The following is a description of a gene set: studied in species Homo sapiens Genes up-regulated in CD38+ CLL (chronic lymphocytic leukemia) cells. from publication Pepper C, Ward R, Lin TT, Brennan P, Starczynski J, Musson M, Rowntree C, Bentley P, Mills K, Pratt G, Fegan C (PMID 17287849) CD38 expression is an important prognostic marker in chronic lymphocytic leukemia (CLL) with high levels of CD38 associated with shorter overall survival. In this study, we used gene expression profiling and protein analysis of highly purified cell-sorted CD38(+) and CD38(-) chronic lymphocytic leukemia cells to elucidate a molecular basis for the association between CD38 expression and inferior clinical outcome. Paired CD38(+) and CD38(-) CLL cells derived from the same patient were shown to be monoclonal by V(H) gene sequencing but despite this, CD38(+) CLL cells possessed a distinct gene expression profile when compared with their CD38(-) sub-clones. Importantly, CD38(+) CLL cells relatively over expressed vascular endothelial growth factor (VEGF) and appeared to preferentially utilize an internal autocrine VEGF survival loop. Elevated VEGF expression was associated with increased expression of the anti-apoptotic protein Mcl-1. Inhibition of VEGF receptor signaling also resulted in a reduction in cell viability. In contrast, exogenous VEGF caused a significant increase in CD38(-) CLL cell viability and a marked induction of Mcl-1; both effects were less obvious in CD38(+) CLL cells. Taken together, our data provide a biological rationale for the poor prognosis of CD38(+) CLL and indicate that both VEGF and Mcl-1 may prove to be useful therapeutic targets. Human Gene Set: PEPPER_CHRONIC_LYMPHOCYTIC_LEUKEMIA_UP, and this is the list of marker genes: ATP10A, OR1E1, ADGRL1, CST3, HTR1B, RPE65, TYRP1, PTN, PGAP1, XYLB, LILRA1, VEGFA, DCAKD, IL1B, TLR3, PADI4, KIR3DL1, LYZ, KIF26B, PLS3, CD38, HTR7, CXCL2, H3C1, CEBPD, EPB41L3, GLP2R, S100A8, IGFBP7, CCL3, AOAH, CSTA